The following is a description of a gene set: Genes having at least one occurence of the motif AGCTCCT in their 3' untranslated region. The motif represents putative target (that is, seed match) of human mature miRNA hsa-miR-28 (v7.1 miRBase). Human Gene Set: AGCTCCT_MIR28 species: Homo sapiens, and this is the list of marker genes: SEH1L, PTPRF, HNRNPK, MEF2D, MAX, SH3D21, CABP7, ZC3H12B, PDZD4, CRIM1, SRSF5, NRAS, UNC5A, CYTH2, RHO, ATXN1, LSM12, LBH, EPHB1, IKZF4, QKI, NR4A3, CDC42SE1 (NCBI Gene Id 56882), CCDC71L, MTSS1, ARK2C, SRF, CSNK1G1, YPEL3 (yippee like 3), CAPRIN1, AMPH, CAPN6 (calpain 6), LUZP1, ACHE, MORF4L2, NNAT, MAP3K3, IQSEC2, ADGRL1, TNFSF12, SSRP1, KDM5C, TLN2, TMEM200B, ARID1A, HTRA2, MSL2, NAA60, NDRG2, AMIGO1, GARRE1 (granule associated Rac and RHOG effector 1), KAT6A, MOSMO, SPRY3, RREB1, CLK3, MAT2A, LRRC14, SDC1, TXNL1, DPF1, DMRTC2, TRIT1, OTUB1, GPM6A, WIPF2, LIF, DDX39A, CNTFR, CSF1, N4BP1, RAP1B, TRPS1, USP9X, HOXA1, SP140L, ZNF512, BCAM, SMAD3, METTL17, FOXN3, SSH2, ZNF569, VAMP2, SARM1, DYRK1A, SETDB1, EN2, BIVM, RCVRN, NDE1